The following is a description of a gene set: Mouse Gene Set: GOBP_NEGATIVE_REGULATION_OF_SCHWANN_CELL_PROLIFERATION species: Mus musculus Any process that decreases the frequency or extent of the multiplication or reproduction of Schwann cells, resulting in the expansion of their population. Schwann cells are a type of glial cell in the peripheral nervous system., and this is the list of marker genes: Dicer1, Fas, Ascl2, Rnf10, Sox10, Cers2 (NCBI Gene Id 99568), Nf1, Ski, Nf2